Given this list of marker genes CASP9, DAPK3, UNC5A, MAGED1, DAPK1, UNC5B, DCC, DAPK2, APPL1, CASP3, here is a description of the gene set: studied in species Homo sapiens Human Gene Set: REACTOME_CASPASE_ACTIVATION_VIA_DEPENDENCE_RECEPTORS_IN_THE_ABSENCE_OF_LIGAND Caspase activation via Dependence Receptors in the absence of ligand